The following is a description of a gene set: Bruton's tyrosine kinase (Btk) is important for B lymphocyte development. To identify genes that are differentially expressed in primary B cells lacking functional Btk, splenocytes from X-linked immunodeficiency (Xid), Btk knockout (KO) and immunocompetent CBA mice, were used in microarrays containing more than genes and expressed sequence tags (ESTs). We found 4515 transcripts expressed in duplicate experiments in all three strains. Out of these, 38 were differentially expressed genes (21 up-regulated >2 fold and 17 down-regulated <-2 fold) between CBA and Btk defective mice. Ten out of these genes were selected and quantitative Real-Time PCR was conducted for validation and further investigation. Real-Time experiments correlated nicely with the microarray data. No definitive phenotypic difference has previously been reported between Xid and Btk KO mice. We found genes, whose expression differed (>2 fold) between the two strains. Moreover, when the genes, which differed between immunocompetent CBA and Btk defective mice were ranked according to fold-increase, the levels in Btk KO mice were significantly more altered. This suggests that the defect in Btk KO mice is more severe and demonstrates that the mutant Btk protein in Xid mice does not generally function as dominant negative form. studied in species Homo sapiens Genes down-regulated in comparison of primary splenic B cells from Xid mice versus those from BTK knockout mice. Human Gene Set: GSE2826_XID_VS_BTK_KO_BCELL_DN from publication Lindvall JM, Blomberg KE, Berglöf A, Yang Q, Smith CI, Islam TC (PMID 15214046), and this is the list of marker genes: SPIC, CCL1, DBNDD2, VNN2, UBD (ubiquitin D), ABCC5, CLDN6 (NCBI Gene Id 9074), ATP6V1A, LEPROT, PPIC, PRKCA (NCBI Gene Id 5578, protein kinase C alpha), CD160, RAB3D, TEX261, IL1A, CLIP3, BARX1, MLLT11, F11R, EMP2, SNRPD2, CD3D, IL2RG, BLVRA, HMGB2, PLP1, AKR1A1, CHMP4B, CAMP, LYRM2, MT2A, AADAC, OR2C1, CYB5R1, PARL, CA3, AATK, LY6E, S100A8, CPQ, MGST1, INVS, TYRO3, UGCG, EBI3, VHL, NAV1, PTPN22, PFKP, C3, TCAP, MVP, ITM2B, UPK2, RBM22, MYCN, COPRS, GSTK1, RACGAP1, GSTO1, IGHG1, CD247, THRB, AP1B1, FECH (ferrochelatase, NCBI Gene Id 2235), BST1, AFF4, CMPK1, CLN6, CAMLG, MXD3, UGDH, CD3G, IL2, AIF1, WASHC3, FAP, STK19, MMUT, CIP2A, BRCA2, KCNK4, NHLH1, ITK, GABRA6, IDUA, CASP7, SOX7, NOTCH4, PRNP, KIFC1, ACTN1 (NCBI Gene Id 87), EPN2, ADA (adenosine deaminase), MYO9A (myosin IXA), SIRPA, MINPP1, MAP7, CPD, PLAUR, PDX1, CKS1B, EPAS1, SDF2, ACO1, ORM2, CAVIN2, USP3, SLC39A9, PKP1, TUBA1C, BCL2L13, UGT8, MYEF2, CSTF3, DLX2, MAP1LC3A, FSHR, PLA2G7, AP2A2, TM2D1, CCL2, APOA2, CDC6, GCSH, ITGA3, CCL13, FMO1, GOLGA7, SDHD, WLS, CFP (complement factor properdin), IRF1, ABCG2, S100A9, ITM2C, COQ10A, GNA12, IFIH1 (NCBI Gene Id 64135), COMT, CMBL, PTPRA, IL10RB, PROS1, LAT, VCAM1, KCNN4, NAP1L2, APCDD1, GNL3, ATAD3A, LCN2, GABARAPL1, TENM4, ETFB, KRTAP12-2, MSTN, INCENP, TM9SF3, CD2AP, ATP1B3, SELE, NRP1, TXK, NUSAP1, RIT1, NME4, EEF2K, B3GALT2, IKBKG (NCBI Gene Id 8517), SERPINB6, DAGLB, ANXA4, HBA2, ICAM5, HBB, SLC6A3, IGFBP4, PPARG, TAP1, PPM1B, ETNK1, INPP5B, TUFM, PAQR7, GLRX, CADM1, EPOR, PRIM1, SBF2, HP, SH2D1A, DOK2, TMEM266, CCNB2, SERPING1, MYO1D, RRM2, TOP2A, DDHD2